Given this list of marker genes Sod2, Cygb, Nqo1, Sod1, Sod3, here is a description of the gene set: Mouse Gene Set: GOMF_SUPEROXIDE_DISMUTASE_ACTIVITY Catalysis of the reaction: 2 superoxide + 2 H+ = O2 + hydrogen peroxide. studied in species Mus musculus